Given this list of marker genes Akr1b1, 4833438C02Rik (NCBI Gene Id 226174), Cpeb1, Chst1, 4930403O18Rik, Pck2, Nmt2, Dgcr6, Wnt4, Elmo1, Ing5, Cst6, Mtm1 (X-linked myotubular myopathy gene 1), Zcchc2, Tmem243, Serpinb8, Gsta4, Dus4l, Rps6ka2, Rnf128, Fam171b, Slc6a8, Lrch2, Etv1, Wdr62, Ahnak, Megf10, Rab39b (RAB39B, member RAS oncogene family), Ccdc91, Nsd2, Vcan, Arl14ep, Dyrk3, Cpox, Gpr19, Ess2, Gch1, here is a description of the gene set: Mouse Gene Set: GAUSSMANN_MLL_AF4_FUSION_TARGETS_G_DN from publication Gaussmann A, Wenger T, Eberle I, Bursen A, Bracharz S, Herr I, Dingermann T, Marschalek R (PMID 17130830) The reciprocal chromosomal translocation t(4;11) is correlated with infant, childhood, adult and therapy-related high-risk acute leukemia. Here, we investigated the biological effects of MLL.AF4, AF4.MLL or the combination of both reciprocal fusion proteins in a conditional in vitro cell culture model system. Several parameters like cell growth, cell cycling capacity, apoptotic behavior and growth transformation were investigated under physiological and stress conditions. Co-transfected cells displayed the highest resistance against apoptotic triggers, cell cycling capacity and loss-of-contact inhibition. These analyses were complemented by gene expression profiling experiments and specific gene signatures were established for each of the three cell lines. Interestingly, co-transfected cells strongly upregulate the homeobox gene Nanog. In combination with Oct4, the Nanog homeoprotein is steering maintenance of pluripotency and self-renewal in embryonic stem cells. Transcription of Nanog and other stem cell factors, like Oct4 and Bmi1, was verified in biopsy material of t(4;11) patient cells which express both reciprocal t(4;11) fusion genes. In conclusion, the presence of both reciprocal MLL fusion proteins confers biological properties known from t(4;11) leukemia, suggesting that each of the two fusion proteins contribute specific properties and, in combination, also synergistic effects to the leukemic phenotype. Down-regulated genes from the set G (Fig. 5a): specific to cells expressing both MLL-AF4 and AF4-MLL fusion proteins. species: Mus musculus